The following is a description of a gene set: from publication Longo NS, Lugar PL, Yavuz S, Zhang W, Krijger PH, Russ DE, Jima DD, Dave SS, Grammer AC, Lipsky PE (PMID 19023113) Sorted B cells using flow cytometry. CD19 selected B cells were sorted using flow cytometry. Genes up-regulated in comparison of germinal center B cells versus memory B cells. species: Homo sapiens Human Gene Set: GSE12366_GC_VS_MEMORY_BCELL_UP, and this is the list of marker genes: SMARCB1, MAPRE1, BACH2, HSPA2, VDR, SERF2, CENPM, TIMELESS, GCSAM, ZNF827, MACROH2A1, GINS1, DNMT1, ENPP3, ANAPC15, AK3, SGK1, SPATS2, ASRGL1, MPC2, EIF3A, E2F3, CAMK2D, MED20, HELLS, KIF4A, METAP2, HACD2, SRSF3, DHX15, SPC25, MAP2, CEP152, POU2AF1, GNA13, TRMT5, SPC24, PIK3CG, FBXO43, PSRC1, ZWILCH, FBXO10, LMNB1, MYBPC1, PARP1, RAB30-DT, DNASE1, IRF8, ZNF280C, VNN2, SPAG5, SYCE1L, SMS, DBI, PSMD14, SCG5, EHD4, TPP2, GSTA4, ST14, MCM10, HPRT1, DPY19L2, NET1, RASAL1, CD81, YEATS2 (YEATS domain containing 2), RABGAP1, CCDC18, OTULIN, CLIC4, ASB13, HMGB2 (high mobility group box 2), C5orf34, SNX30, APOLD1, MCM7, SFPQ, TUBA1C, ZNF215, SUGCT, TACC1, PTP4A2, PMS2P11, ZNF738, VGLL4, MCM2 (minichromosome maintenance complex component 2), CALML4, USP32P2, MCM3, HNRNPK, ANKRD36BP2, ZNF608, DTL, ROMO1, ZFAND6, MAP4K4, LRIG1, CDC7, ESRRB, UHRF1, WAPL, HNRNPA1, COP1, SAE1, KLHL5, ALYREF, BCAT1, SPI1, GSTZ1, ZNF141, CDCA2, KIF20A, CENPF, ATP2A2, DMD (dystrophin), SERPINA9 (NCBI Gene Id 89779), RBM17, AMZ2P1, REXO5, UCP2, SLC25A5 (solute carrier family 25 member 5), CTTN, SPINK2, APOM, TPX2, SLC39A8, CCDC117, PEG10, TK1, MET, XPNPEP1, CD79B, RRM2B, ZGRF1, ARHGAP33, TCL1B, ROR1, GALNT14, FAM76B, G3BP1, TXNDC16, CFAP251, PSMA4, EIF4H, TCL6, PLK4, TMPO-AS1, ELAVL1, TXN2, ATAD2, ROCK2, ODC1, SYNE2, ARHGAP28, NCBP3, IRAG2, CSK, RAD51, GPR160, TMCO3, UBE2J1, AFF2, TUBB2A, SWAP70, DDHD1, C12orf75, MCM4, RAD54L, CHAMP1, LMO2, CHEK1, RNFT2, DEPDC1B, SNX5, ZFAND4, FGF20, BLOC1S6 (NCBI Gene Id 26258), TUBB3, TMEM106C, CCDC88A, PBK, STK40, TUBA1B, MBOAT2, TCL1A, CDCA5, STRAP, SYBU, VRK1, RNF19B, DNAI4, BASP1, RSU1, CDC20, SLC35E3, GPR84, SAP130